Given this list of marker genes Nans, Ric8a, Zfpm1, Tubb4b, Pnpla2, Pycr2, Wdr46, Grwd1, Crtc3, Phb1, Emc4, Bop1, Vrk3, Naa16 (NCBI Gene Id 66897), Pfn1, here is a description of the gene set: Mouse Gene Set: CUI_NK_CELL_CD40L_RESPONSE_UP from publication Cui A, Huang T, Li S, Ma A, Pérez JL, Sander C, Keskin DB, Wu CJ, Fraenkel E, Hacohen N (PMID 38057668) Cytokines mediate cell-cell communication in the immune system and represent important therapeutic targets. A myriad of studies have highlighted their central role in immune function, yet we lack a global view of the cellular responses of each immune cell type to each cytokine. To address this gap, the authors created the Immune Dictionary, a compendium of single-cell transcriptomic profiles of more than 17 immune cell types in response to each of 86 cytokines (>1,400 cytokine-cell type combinations) in mouse lymph nodes in vivo. A cytokine-centric view of the dictionary revealed that most cytokines induce highly cell-type-specific responses. For example, the inflammatory cytokine interleukin-1β induces distinct gene programmes in almost every cell type. A cell-type-centric view of the dictionary identified more than 66 cytokine-driven cellular polarization states across immune cell types, including previously uncharacterized states such as an interleukin-18-induced polyfunctional natural killer cell state. species: Mus musculus Genes positively differentially expressed in cell type: NK cell upon treatment with cytokine: CD40L in mouse lymph nodes in vivo.